The following is a description of a gene set: To elucidate gene expression pathways underlying age-associated impairment in influenza vaccine response, we screened young (age 21-30) and older (age >= 65) adults receiving influenza vaccine in two consecutive seasons and identified those with strong or absent response to vaccine, including a subset of older adults meeting criteria for frailty. PBMCs obtained prior to vaccination (Day 0) and at day 2 or 4, day 7 and day 28 post-vaccine were subjected to gene expression microarray analysis. We defined a response signature and also detected induction of a type I interferon response at day 2 and a plasma cell signature at day 7 post-vaccine in young responders. The response signature was dysregulated in older adults, with the plasma cell signature induced at day 2, and was never induced in frail subjects (who were all non-responders). We also identified a mitochondrial signature in young vaccine responders containing genes mediating mitochondrial biogenesis and oxidative phosphorylation that was consistent in two different vaccine seasons and verified by analyses of mitochondrial content and protein expression. These results represent the first genome-wide transcriptional profiling analysis of age-associated dynamics following influenza vaccination, and implicate changes in mitochondrial biogenesis and function as a critical factor in human vaccine responsiveness. species: Homo sapiens from publication Thakar J, Mohanty S, West AP, Joshi SR, Ueda I, Wilson J, Meng H, Blevins TP, Tsang S, Trentalange M, Siconolfi B, Park K, Gill TM, Belshe RB, Kaech SM, Shadel GS, Kleinstein SH, Shaw AC (PMID 25596819) Genes up-regulated in peripheral blood mononuclear cell 2d vs 0d in seniors (70+) (nonresponder) after exposure to Inactivated influenza vaccine, time point 2D Human Gene Set: THAKAR_PBMC_INACTIVATED_INFLUENZA_AGE_70PLS_NONRESPONDER_2DY_UP, and this is the list of marker genes: RBM34, LARP4, BOLA3, PTPN4, SAR1B, NUP43, CCDC167, NOSIP, DNAJB14, RRM1, VPS37A, TRA2B, TMEM14B, LSM5, CDC42SE2, STK26, DYNLT3, ZNF146, MED31, LYRM7, MSMO1, ZNF91, TAPT1, FAM98A, YEATS4, RLIG1, ECI2, ASF1A, AGL, LEPROTL1, TBPL1, PRKAA1, RPS6KA5, ZNF654 (zinc finger protein 654), SRPRB, DENND1B, TRAK2, COBLL1, CD24, CD160, C12orf57, TARS1, ZNF260, PCMTD1, USP38, PPP6R2, SCOC, USO1, DIPK1A, ROMO1, MTF2, PURA, FKBP5, RPL14, UBE2Q2, LEMD3, PNP, SLC38A2, RNGTT, NTRK1, NUP54, FAM133B, SMARCA5, FAM107B (family with sequence similarity 107 member B), GON7, GART, OCIAD2, TMCO1, CCDC34, THNSL1, SYTL2, CCNB1IP1, SP4, UBLCP1, BLOC1S5, AIDA, CISD1, FYTTD1, SEC62, ERGIC2, MIX23, CKS2, RPL23, LDHB, SEPTIN7, ACTR6, CEBPZ, DYNLL1, TEX30, VPS26A, HACD3, SOCS2, RPP40, SDHAF3, MCM6, USP1, IFT74, TC2N, DPY30, SAR1A, TSC22D2, PPP4R3B, THEMIS, VBP1, STAP1, NRBF2, PPM1B, PUS3, BTLA, CCDC32, UGCG